The following is a description of a gene set: Any process that activates or increases the frequency, rate or extent of relaxation of muscle. Mouse Gene Set: GOBP_POSITIVE_REGULATION_OF_RELAXATION_OF_MUSCLE species: Mus musculus, and this is the list of marker genes: Nppc, Abcc8, Hrc, Pawr, Chga